Given this list of marker genes Sptbn1, Tsc1, Flcn, Cdkn2c, Pten, Dkc1, Tsc2, Nf2, here is a description of the gene set: Mouse Gene Set: MP_INCREASED_RENAL_CARCINOMA_INCIDENCE from publication Motenko H, Neuhauser SB, O'Keefe M, Richardson JE (PMID 26092688) Mouse genes annotated to increased renal carcinoma incidence (MP:0010384) retrieved from the Mouse Genome Informatics database via MouseMine species: Mus musculus